The following is a description of a gene set: The lipid bilayer surrounding an azurophil granule, a primary lysosomal granule found in neutrophil granulocytes that contains a wide range of hydrolytic enzymes and is released into the extracellular fluid. Human Gene Set: GOCC_AZUROPHIL_GRANULE_MEMBRANE studied in species Homo sapiens, and this is the list of marker genes: VNN1, TOM1, ABCA13, RAB37, CPNE1, TMEM30A, ATP6V0C, CEACAM8, SLCO4C1, DDOST, MGST1, SNAP29, SYNGR1, ATP11B, HLA-H, CMTM6, LAMTOR1, PSAP, VAMP1, NCSTN, FPR1, AZU1 (NCBI Gene Id 566), NDUFC2, STOM, VAMP7, IRAG2, GLIPR1, RAB3D, PSEN1, ATP8A1, PRCP, RAP1B, CEACAM6, DNAJC13, CPNE3, LAMP1 (NCBI Gene Id 3916), LPCAT1, MAGT1, PIGR, SURF4, GAA, RAB44, BRI3, VAMP8, VAPA, DNAJC5, B4GALT1, LAMP2 (lysosomal associated membrane protein 2), NFAM1, MANBA, ARL8A, CD63, CD68, RAB5C, BST2, C3AR1, TMEM179B, CKAP4, ACP3